The following is a description of a gene set: Any process that activates or increases the frequency, rate or extent of reactive oxygen species metabolic process. Human Gene Set: GOBP_POSITIVE_REGULATION_OF_REACTIVE_OXYGEN_SPECIES_METABOLIC_PROCESS studied in species Homo sapiens, and this is the list of marker genes: GRIN1, DUOXA2, PLCG2, F2, TLR6, GRB2, CD177, DUOXA1, PRKCE, SNCA, ACOD1, NOX5, APP, DCXR, AGT, AKR1C3 (aldo-keto reductase family 1 member C3), TGFB1, ADGRB1, CYBA, FOXO3, ZC3H12A, ITGB2, SIRPA, PARK7, RAB27A, RIPK1, MAPT, CBR1, LCN2, ITGAM, GNAI2, F2RL1, CDKN1A, LEP, CLCN3, RNF41, PDGFRB, MIR24-1, FPR2, ZNF205, GSTP1, PID1, PDGFB, ADCY10, CLEC7A, SYK, TP53, ROMO1, TYROBP, SLC5A3, CRP, NNT, TSPO, MAPK14 (mitogen-activated protein kinase 14), SOD1, RIPK3, THBS1, AKR1C1, MIR675, NFE2L2, DHRS4, PRKCD, ACE2, SOD2, AGTR1, ELAVL1, CD36, TGFBR2, GADD45A, TLR4, FAS